The following is a description of a gene set: Human Gene Set: GOCC_PHAGOCYTIC_VESICLE species: Homo sapiens A membrane-bounded intracellular vesicle that arises from the ingestion of particulate material by phagocytosis., and this is the list of marker genes: HLA-E, HGS, ATP6V0C, CYBB, OCRL (OCRL inositol polyphosphate-5-phosphatase), RAB8B, FLNB, RAB11FIP5, RAB23, AMBRA1, LAMP2, ZDHHC5, RAB5A, LTF (lactotransferrin), STX6, NCF2, STX4, CLEC4E, NCF1, DNM2, TAPBP, RAP1A, MCOLN1, CD82, VAMP4, TLR6, CLCN3, RAB7A, VAMP8, CDC42, BECN1, INPP5B, ATP6V0E1, PIK3R4, HLA-H, TAP1, VIM, HVCN1, PIP4P1, SRGAP2, PDIA3, ATP6V0E2, ATP6V0B, RAC2, CD36 (NCBI Gene Id 948), PIKFYVE, TLR1, ELANE, SLC11A1, RAB22A, CDC42EP2, RAB31, RAB32, WAS, SNX3, FMNL1, PGLYRP1, PIK3C3, ANXA3, RAB7B, UNC93B1, CORO1A, RAB8A, STXBP1, RAB11B, CTSS, STXBP2, STXBP3, NOD1, ZYX, RAB34, RAB10, RAB11A, TLR7, VAMP3 (NCBI Gene Id 9341), RAB9B, DMBT1, ITGAV, RAB9A, LAMP1, STXBP4, LRRK2, SLC9A9, MPO, SNAP23, HLA-A, UVRAG, TLR9, VAMP7, SYT11, SLC15A2, HLA-F, PLA2G5, ATG5, ACTG1, ABCA1, SLC48A1, ATP7A, VPS26B, TCIRG1, SCIMP, TAP2, ADAM8, ATP6V0A2, MTMR4, RAB39A, TRIM14, SYK, MYO1C, RILP, ATP6V0D2, ITGB5, PIP4P2, SEC22B, B2M, RAB43, TLR2, HLA-B, HLA-G, GSN, SYT7 (synaptotagmin 7), RAB38, CDC42EP4, NCF4, RAB20, NOD2, SLAMF1, MTOR, STX12, GNLY, ATG14, ATP6V0D1, ATP6V0A4, ATG12, APPL1, MPEG1, STX8, ATP6V0A1, IRGM, CALR, ANXA11, RAB11FIP1, KIF5B, HLA-C, PLD4, RAB14, APPL2, CYBA